The following is a description of a gene set: Genes having at least one occurrence of the motif NNRYCACGTGRYNN in the regions spanning 4 kb centered on their transcription starting sites. This matches the transcription factor binding site V$USF_01 (v7.4 TRANSFAC). Human Gene Set: USF_01 studied in species Homo sapiens, and this is the list of marker genes: CUL5, HOXB5, NAA50, NEUROD1, C9orf85, XPO1, RMND1, THUMPD2, KDM4C, HOXA7, NIT1, PSME3IP1, PRPS1, RARG, PLEKHA6, EIF4B, DUSP1, HOXA9, HNRNPD, IGSF22, ZMYND12, MTCH2, ORAI2, RAB24, ANKRD12, COMMD3, GGN, CPT1A, COMMD8, EIF3A (NCBI Gene Id 8661), TOM1, RGL1 (NCBI Gene Id 23179), PPP1R3C, ETV1, CNPPD1, ELAVL3, RBM15B, CIPC, UTY, HOXB7, BOK, ILF3, HOXA11, GSK3B (glycogen synthase kinase 3 beta), MANF, RPA1, ADAM10, ARPC5 (NCBI Gene Id 10092), RSPRY1, KCNH4, SYT3, HOXA1 (homeobox A1), SET, TOM1L2, NPTX1, SC5D, HNRNPH2, RANBP1, POGK, TMEM132E-DT, SUMF1, HOXC5, FAM13B, EIF4E, SLC36A1, EME1, SNX5, GIGYF2, SLC26A2, LNPK, CGN (cingulin), FMR1, MAX, ALG1, ATF4, AKAP1, UBXN10, BDNF, RNF115, PHF20L1, ESRP2, RPL13A, USP31, ALDH6A1, USP15, POLR3C, TFAP4, DOHH, MCOLN1, TEF, DENND6A, TOGARAM1, GABARAP, KAT6A, ZCCHC7, HPS5, DHX35, MGME1, TMEM108, DIP2B, KBTBD2, ZNF318, SLC1A7, EPC1, TRMT2A (tRNA methyltransferase 2 homolog A), KDM6A, GNA13, CD164, RETREG2, C1orf43, MON1A, IGF2R, VGF, SMYD4, ILF3-DT, BRDT, SASH3 (SAM and SH3 domain containing 3), BATF3, HOXD10, FSHR, BAX, IRF9, SMC3, RAPGEF6, ZNF503, ESR2, BHLHE41, PHF20, CLUH, SSR1, GNAS, NUDC, HAPSTR1, SLC49A4, RLF, DVL2, TRMO, PRDM4, SEPTIN3, APEX1 (apurinic/apyrimidinic endodeoxyribonuclease 1), ZBTB8OS, SLC38A2, GTF2A1, ODC1, AMDHD2, HMGN2, ABHD17B, TAF6L, DDX3X, KLHL28, HMOX1 (NCBI Gene Id 3162), NFX1, VPS33A, CCAR1, CLN3, STX6, HOXC11, MORF4L2, MCM2, NPM1, AFF4, SLC12A6, ATP6V1A, ATIC, TESK2, BMP4 (bone morphogenetic protein 4), HPS3, PLCG2, ATF7IP, SIGMAR1, PHC3, SIRT1, VPS26A, SHOC1, IRS4, RAD9A, RAB3IL1, PKN1, PPM1A, TSC1, GYG1, DOLK, DRC3, TIMM8A, KAT5, DEPDC7, IGF2BP1, PFDN2, HSPBAP1, SAE1, DUSP7, COPZ1, RNF146, PRELID1, ARMCX6, CHD4, LYPD1, GTF2H1, MRPL27, SEC11C, TMEM132E, EIF4G1, OSGEP, OGDHL, VPS16, GNB2, HOXB4, TSR2, TTLL6, ARMT1, LAMP1, LONRF3, KAT14, TADA1, CBX6, TFRC, TRIM37, RBBP6, SCYL1, PCED1A, HNRNPA3, SLC31A2, METAP1D, GPX1, NRIP3, VPS37B, FEN1, DCTN4, NDUFS1, RAB31, TMEM258 (transmembrane protein 258), EEF1B2, PER1, RALYL, ZFYVE26, B3GNT9, DNMT3A, RBBP4, STMN1, AMMECR1L, RAI14, AP1S2, AATF, OPRD1, FOXD3, PTMA, PCDHA10, GLA, TOPORS, CUTA, AKAP10, PICALM, U2AF2, PPCS, TCEAL3, UBE4B, TRIM55, ATXN3, BRD2, GATA5, AKAP12, PDIA2, UBE2B, SGO1